The following is a description of a gene set: Ligand-dependent activation of the hedgehog (Hh) signalling pathway has been associated with tumorigenesis in a number of human tissues. Here we show that, although previous reports have described a cell-autonomous role for Hh signalling in these tumours, Hh ligands fail to activate signalling in tumour epithelial cells. In contrast, our data support ligand-dependent activation of the Hh pathway in the stromal microenvironment. Specific inhibition of Hh signalling using small molecule inhibitors, a neutralizing anti-Hh antibody or genetic deletion of smoothened (Smo) in the mouse stroma results in growth inhibition in xenograft tumour models. Taken together, these studies demonstrate a paracrine requirement for Hh ligand signalling in the tumorigenesis of Hh-expressing cancers and have important implications for the development of Hh pathway antagonists in cancer. Genes down-regulated in mouse stroma of pancreatic adenocarcinoma zenografts after treatment with HhAntag, a hedgehog (Hh) pathway inhibitor. Mouse Gene Set: YAUCH_HEDGEHOG_SIGNALING_PARACRINE_DN species: Mus musculus from publication Yauch RL, Gould SE, Scales SJ, Tang T, Tian H, Ahn CP, Marshall D, Fu L, Januario T, Kallop D, Nannini-Pepe M, Kotkow K, Marsters JC, Rubin LL, de Sauvage FJ (PMID 18754008), and this is the list of marker genes: Vmn2r129, 4930444F02Rik, Ube2q2l, Npy2r, A530020G20Rik, Col4a4, Gm10421, Ankrd23, Cenph, 2700099C18Rik, Tnr, Smtnl1 (NCBI Gene Id 68678), 1700013G24Rik, Ttn, Cfap206, Slc25a41, Myl1, Bclaf1, Ttr, Atp2a1, 4930509E16Rik, Usp17lc, Relch, 9030607J07Rik, Arpp21, Fabp6 (NCBI Gene Id 16204), Scrg1, Myf5 (NCBI Gene Id 320915), Ncan, Tex16, Aqp5, Kcnd2 (NCBI Gene Id 97339), Coro6, Pdlim3, Spata16, Garin3, Apom, Myf6, Dlk1, Kcnk9, Sntg1, Treh, Mc1r, Tmed7, B3galt1, Zfp729a (NCBI Gene Id 212281), Ikzf3, Zswim5, Meiob, Nphp3, Slc15a5, 4930524C18Rik, Ryr2, Thoc7, Gm19605, Col12a1, Clhc1 (clathrin heavy chain linker domain containing 1), Hif1a, Lce1h, Gh, B3galt6, Daam2 (NCBI Gene Id 76441), Mybpc1, Sprr2a1, Ctsm, Klhl41, Pbx4, Trim7, Gm15295, Id4, Lenep, 1110015O18Rik, Als2, 5730420D15Rik, Smo, Cyp1a1, Tff2, Gdpd3, Potegl, 8030456M14Rik, 4930415O11Rik (RIKEN cDNA 4930415O11 gene), Tnip2, Ddo, Ascl1, Sh3bgr, Dglucy, Myh1, Gm29183, Mrap2, Hspa4l, Tex21, Pramel34, Pms2, 4930408K08Rik, Odad3, Asb15, Npas3 (NCBI Gene Id 71644), 0610040J01Rik, Susd5, Chrna6, Gm47252, Nrsn1, Ak4, 6820445E23Rik, Gm8479, Tnnt3, Prdm16, Farsa, Trim63, Gm39079, Focad, Wnt3, 6330403L08Rik, Trim17, Trat1, Gm7967 (NCBI Gene Id 674994), Kcnj3, Nexmif, Lrp2bp, 4930473O22Rik, Gabra2, Tas1r3, Myh4 (NCBI Gene Id 544788), Gm4251, Cd28, Pax9 (NCBI Gene Id 18511), C79798, Cecr2, Eya1, Tmod4, Pcdh9, Sim1, 5430430B14Rik, Hepacam, Gm11544, Rbm14, Rhag, Isl1, ENSMUSG00000128334, Tnni2, Usp53, Prox2, Coa7 (NCBI Gene Id 69893), Casq2, Bmal2, 2210409D07Rik, Speg (NCBI Gene Id 98673), Pcdh10, A330008L17Rik, Gm15535, Ctsj, Cacna1b, Cabp7, Skor1, Zic5, Nlrp4f, Polq, Kyat1, Osbpl6, Mettl21e, 4930503E14Rik, Or5b106, Slc29a4, Ube2u, Fcrl1, Ptprj, Mylpf, Ckm, Neb, Fastkd3, Cep128, Mmp13, Pot1a, Mybpc2, Ripk4, Tnp1, Magea7-ps, Chrna9, Rad54b, Stac3 (NCBI Gene Id 237611), Myom2, Elfn2, Tnnt2, Nmbr, 4930533K18Rik, Slc5a12, Lrrc39, Psrc1, Krt6b, Grip1, Sema3b, Cftr, Rufy2, Nr6a1, Il16, Serpinb2, 6430571L13Rik, Utp23, Smyd3, Acta1, Pvalb, Htr7, Chil4, AI507597, Flrt2, Ehf, Kbtbd6, Adora2a, Cpa6, Epha1, 4933432K03Rik, Nectin3, BC030500, Pip5k1b, Dynlt1a, 1700017G19Rik, Mypn, Defb8, Or2t45, Pygm, 4933435G04Rik, Thbs4, Ceacam11, Cux2, Itsn1, D630023F18Rik, Ms4a2, Gm15918, Crat, Mgat5, Rbfox1 (RNA binding protein, fox-1 homolog (C. elegans) 1), Dhcr24, Smim17, 2310069G16Rik, Kcnk1, Gabrb1, Gria1, Upk1b, Lrrtm2, Nxph1, 2900060N12Rik, Serpinb5, Fabp1, Pou3f1, Clec2i, Mb, 9430091E24Rik, Spaca7, Zic1, Sln, Ccdc34 (coiled-coil domain containing 34), Semg1, Pappa, Hapln1, Tnnc2, Cadm2, Them5, Adgra1, D5Ertd579e, Slc25a27, Kcnh2, Tbr1 (NCBI Gene Id 21375), Slc22a29, Cimip4, Rpgrip1, Cd27, Prps1l1, Grik1, Sbspon, Fam53a, Timd2, Rln1, Socs2, 1110019D14Rik, Myot, Syt2, Pcnt, Trim12c, Ckmt2, Foxn4, Spmip10 (NCBI Gene Id 67343), Rbm46, Actn2 (NCBI Gene Id 73715), Insm1, Ctxn3, Nav2, Prkca, A2m, 4930449I24Rik, Tmem269, Ncam2, Slc25a26, B230112I24Rik, Otc, Fam131b, Gngt1, Gm38593, Sema3e, Ccdc7b, Ankra2, Serpina1a, Rsph4a, BC061195, Trdn, Dpy19l2, Lipm